Given this list of marker genes TMEM216, MVK, B4GAT1, INPP5E, TCTN3, ALX4, MEF2C, COG8, FKRP, CEP290, TFAP2A, ZEB2, PTF1A, TMEM237, RNU4ATAC, KIF14, PDE6D, KPNA3, here is a description of the gene set: species: Homo sapiens Congenital absence of the vermis of cerebellum. Agenesis of cerebellar vermis Human Gene Set: HP_AGENESIS_OF_CEREBELLAR_VERMIS